Given this list of marker genes ANP32B, RAP2A, ZBED1, COQ5 (coenzyme Q5, methyltransferase), CDC23, AKR1B1, CDK5, IL10RB-DT (IL10RB divergent transcript), IMPDH1, NUDT16L2P, C2orf69, MCM9, PCGF1, PRADC1 (NCBI Gene Id 84279), CMSS1, APOO, KDM2B, NFXL1, CFAP97, CHST7, CCT7, CERK, TTLL5, OLFML2B, NKIRAS1, MRPL34, NAPRT, PPCS (phosphopantothenoylcysteine synthetase), NUTF2, NUP133, RYK, SCD (stearoyl-CoA desaturase), GSTP1, OXLD1, NSMCE3, MCCC1, FAM89B, ZNF664, CSK, EVI5, CUTC, JCAD, DTX4, AFG2B, CH25H, MAPK1, BZW2, AGO1, BTBD6, TRAPPC12, NUP155, PDE8A, ZNF674 (NCBI Gene Id 641339), NDUFAF7, TXNDC16 (thioredoxin domain containing 16), RDH11, BRAT1, AIFM1, CCL26, PSIP1, MIB1, PABIR2, SNX1, COX11, GALNT1 (polypeptide N-acetylgalactosaminyltransferase 1), RARS1, SPG21, KCNK6, MAPKAPK5 (MAPK activated protein kinase 5), MAOA, TMEM14C, RIC8A, POU2F2, CDC40, SIGLEC17P, ECH1, MCM6, KCNE1, ETFB, GAB3, ACAD9 (NCBI Gene Id 96656), PKD2, SURF1, MAF, MRPL2, TRMT61B, NDUFA8, AASDH, GFM1, HERC3, TNRC6B, CCL17, TULP4, HSD17B4, ACOX3, ZZEF1, RIOK2, TMEM170B, SARAF, ZFP36L1, RNH1, CHML, HDHD5, ACAD8, HDGF, LMNA, SNX30 (NCBI Gene Id 401548), AKAP11, SOCS6, FBXO9, PDPK1, UMPS, RANBP6, SLC47A1, NCOR1, UBAC1, UTP18, STIM2, TKT, MPHOSPH8, ADI1, PTGER2, PRPF31, MCM5, IMPACT, FBXO42, ZNF585A, APEX2, DTYMK, COMMD1, TMEM52B, LCP1, EPHX1 (epoxide hydrolase 1), GRK3, NT5DC2, MS4A4A, PAXBP1, CCL22, FAM221A, KCTD11, COMMD3, TTC9C, OSGEP, CEP164 (NCBI Gene Id 22897), PRPS1, KMO, MKRN1, KIAA2013, PLAGL1, EEF2K, NUP85, GAS2L3, HSD11B1 (hydroxysteroid 11-beta dehydrogenase 1), SDF4 (NCBI Gene Id 82832), NAT1, CHCHD7, CNOT6L, ANKMY2, POGLUT1, KLHL9, CLTB, TATDN2, S100P, BCL2L12, IFNAR2, PLA1A, SEPTIN9, ETV6, DCXR, NLRC4, VPS26B, PPP1R7, EEPD1 (endonuclease/exonuclease/phosphatase family domain containing 1), RAB4A, NDUFS1, ZCCHC14, SLC25A3, PPP1R15B, EMC8, ZCCHC17, APCDD1L, FH, SPINT2, NUP93, CPQ, EMB, MCRIP2, PHF10, RPA1, SNX17, MRPS34, NFIC (nuclear factor I C), PHYH, TAPT1, GSTM4, SETD6, TUBG1, BLTP2, MYOT, ACACA, here is a description of the gene set: Genes down-regulated in CD8 alphabeta OT1 thymocyte RTOC culture versus CD8 alphabeta HY thymocyte RTOC culture. from publication Yamagata T, Mathis D, Benoist C (PMID 15133507) Four independent chip hybridization with RNAs from four independent RTOC cultures. Human Gene Set: GSE1112_OT1_VS_HY_CD8AB_THYMOCYTE_RTOC_CULTURE_DN species: Homo sapiens